Given this list of marker genes FCGR2B, CD46 (CD46 molecule), SPINK5, MASP1, A2M, SERPING1, CR2 (NCBI Gene Id 1380), C4BPB, VSIG4, CD59, SUSD4, CD55, FOXJ1, C4BPA, PTPN6, CR1, CR1L, here is a description of the gene set: Human Gene Set: GOBP_NEGATIVE_REGULATION_OF_HUMORAL_IMMUNE_RESPONSE Any process that stops, prevents, or reduces the frequency, rate, or extent of a humoral immune response. studied in species Homo sapiens